Given this list of marker genes IFITM2, SP110, PLTP, FCN1, H2AB2, GTF2F1, PPFIA3, IL36A, TXN, TBR1, HNRNPH2, EHBP1L1, BCL9, VOPP1, SLC25A1, DLD, CHAC2, B4GALT3, PLAGL1, GSC2, PAPPA2 (NCBI Gene Id 60676), FCER1G, SYF2, MT1E, PSMD11, CUL1, ZC3H12D, KATNA1, GTPBP6, ZSWIM5, LENG1, CCNT1 (cyclin T1), ZDHHC21, HSPA5, CCNJ, GNL1, PROCR, CLK3 (CDC like kinase 3), SLC9A8, GNA13, LCK, CRBN, DCN, AIM2, KCNF1, LOX, ZHX2, KARS1, DOT1L, USP42, GDPD1, UGT2B10, SELENOT, IL36RN, ARG2, CDC42BPA, PIAS1, PTPN12, ARMC7, KLHDC3, MED10, ZNF606, SOS1, MRPL3, TIFA, SIPA1L1, CAPZA2, TRMT1L, TMIGD1, POLR3C, SF3B1, SRPRA, ZEB1, GPC1, CYLD (CYLD lysine 63 deubiquitinase, NCBI Gene Id 8010), CYP21A1P, TRIM36, UBN2, SGCB, CLIC6, GMFG, C5orf15, TUT7, NR1H3, SFSWAP, AFF1, TUT1, CWC27, KIAA1614, RAB10, MOV10L1, SCAP, ORAI2, CH25H, SYVN1, ADAMTS4, TMEM219, TP63, SCNN1B, CRISPLD1, TIMP1, TXNDC9, SRP72, GFPT1 (NCBI Gene Id 2673), SWAP70, DPEP3, SLC31A1, HLA-DQA1, ACBD3, METTL6, CCDC25, ANKRD34A, DEDD, LPAR4, GCC1, CCDC80, TMED5, BRWD3, SRFBP1, BAHD1, SOX14 (NCBI Gene Id 8403), VPS37A, HECTD1, SBNO1, IL2RA, OAF, ITPR1 (NCBI Gene Id 619543), DGKA, TRAM2, SUDS3, TNFSF4, PPFIBP1, PRKCG, ARFGAP1 (NCBI Gene Id 55738), CCIN, SLC24A4, NIBAN1, PSEN1, ASS1, FLRT2, HCFC2, RNASE10, S1PR4, ADAM23, ARMCX2, LOXL4, KPNA4, TMEM68, KDM5C, XYLT2 (NCBI Gene Id 64132), CASP7, EYA3 (EYA transcriptional coactivator and phosphatase 3), SH3BP2, JRK, FOXRED1, SELL, ST6GAL2, SWT1, SEC23B, DUS2, RLIM, MACIR, IRF6, TCEA1, ASTN1, DDT, CCDC162P, TTC39C, TMEM184B, LPCAT2, AGTRAP, CREB3, CACNA1D, GABRE, GDAP2, RHOG, PMPCA, AQP9, ZDBF2, GJC1, STBD1, KMT2E, RBL1, STIM2 (NCBI Gene Id 57620), WAC, MAFF, JAK3, SPOP, KIF3C, DLG3, CDC42EP5, STK19, PHF20L1, KDM5D, NSUN7 (NCBI Gene Id 79730), QPRT, MAGOHB, PITPNM1, MSL2, NBAS, here is a description of the gene set: Genes down-regulated in comparison of macrophage cells stimulated with LPS (TLR4 agonist) for 20 min versus macrophage cells stimulated with LPS (TLR4 agonist) for 360 min. from publication Litvak V, Ramsey SA, Rust AG, Zak DE, Kennedy KA, Lampano AE, Nykter M, Shmulevich I, Aderem A (PMID 19270711) The innate immune system is a two-edged sword; it is absolutely required for host defense against infection, but if left uncontrolled can trigger a plethora of inflammatory diseases. Here we used systems biology approaches to predict and validate a gene regulatory network involving a dynamic interplay between the transcription factors NF-κB, C/EBPδ, and ATF3 that controls inflammatory responses. We mathematically modeled transcriptional regulation of Il6 and Cebpd genes and experimentally validated the prediction that the combination of an initiator (NF-κB), an amplifier (C/EBPδ) and an attenuator (ATF3) forms a regulatory circuit that discriminates between transient and persistent Toll-like receptor 4-induced signals. Our results suggest a mechanism that enables the innate immune system to detect the duration of infection and to respond appropriately. Human Gene Set: GSE14769_20MIN_VS_360MIN_LPS_BMDM_DN studied in species Homo sapiens